The following is a description of a gene set: from publication Chen Y, Wang X (PMID 31504780) Genes predicted to be targets of miRBase v22 microRNA hsa-miR-3978 in miRDB v6.0 with MirTarget v4 prediction scores > 80 (high confidence targets). Human Gene Set: MIR3978 studied in species Homo sapiens, and this is the list of marker genes: GRM7, NRXN2, DISC1, ADAMTS9, BTBD8, SOCS3, SP3 (Sp3 transcription factor), MOSMO, STIM2, AP3S2, ATE1, NSD2, TMX4, CBFA2T2, KCNA5, KIAA0408, H2AZ1, SLC36A3, IRF8, ACVR2A, CASD1 (CAS1 domain containing 1), LCP1, ZC3H10, TNC, NETO1, CNOT6L, CLOCK, PKN2 (protein kinase N2), PER3, PHTF2, HACD4, IQCA1, OAS1, TOX, ARHGAP24, DDX6, GATM, NUP43 (NCBI Gene Id 79700), ADM, ANKRD42, CPNE3, RASSF8, HOMEZ, RORA, PURB, HSF5, GALE, GPR19, DPYD, NUFIP2, LMO3 (NCBI Gene Id 55885), DIAPH2, LETM2, POU2AF1, CNBD2, ACSL1, ARID4B, TM4SF4, DNAJB2, ATXN7, EIF5A2, TEAD1, MPC1, HOXD13, KDM3B (NCBI Gene Id 51780), SV2B (synaptic vesicle glycoprotein 2B), DOCK5, ZNF280C, PDE7A, ZNF84, RICTOR (NCBI Gene Id 253260), PRRC2B, GOLT1B, SERPINB8, HGSNAT, PDPK1, OPN3 (NCBI Gene Id 23596), NAMPT, SLC22A23, INSYN2A, ADAMTS5, GPLD1, AVL9, RGS21, RAD21, B3GNT5, ANGEL2, MMS22L, TSPAN2, IARS1, ARHGEF9, CHMP5, SPIN1, ARL1, PDE4DIP, SH3TC2, IER3IP1, KDELR1, PPIP5K2, DCK, ESR1, BMPER, AFF2, TMOD3, MYLK4 (NCBI Gene Id 340156), RCC2, S1PR3, FRMPD4, ARPIN-AP3S2, HOXA1, TLE1, WDR33, ACTL6A, ALPL, C2orf66, ONECUT2, IL1R1, RFXAP, PTPRD, RUNX1T1, SNAP47, HOOK3 (NCBI Gene Id 84376), KDM7A, CCDC3, TMEM132D, ARL10, FCHO2, ATXN3, GNRHR, PSD3, PRICKLE2, CHIC2, DLL1, STXBP6, PPP2R5C, ARSB, GABRA1, MFAP3L, KPNA4 (karyopherin subunit alpha 4), WIPI2, FARP1, GJB7, CCAR2, DNAH10, PPM1H (protein phosphatase, Mg2+/Mn2+ dependent 1H), TAF11, SMIM10, XRN1, IL1RAP, RPS6KA6, LMTK2, PRIMPOL (NCBI Gene Id 201973), PEX7, IMPACT, YPEL2, TRIM2, PTPDC1, AP1S2, MLEC, TRAPPC4, FRMD5, SLC9A9, SRPK2, PRDM16, SRGAP1, NEFH, JAKMIP2, OSBP2, GMCL1, HIPK2, VGLL3, PDE4D, TAPT1, CTXN2 (NCBI Gene Id 400369), ABCD2, ZNF792, PCDHGA7, CNR1, CHL1 (NCBI Gene Id 10752), WNK1, SULT1C2, CLEC7A, IDH3A, LIN7A, ZNF664, EPB41L2, INO80D, GDPD1 (glycerophosphodiester phosphodiesterase domain containing 1), EIF1B, GLRA2, SIT1, ZNF704, PRRG3, LY6G6C (lymphocyte antigen 6 family member G6C), BCAP29, SF3B1, B3GALNT2, LRRTM2, ZW10, KIAA1328, DGKH (NCBI Gene Id 8524), TMEM229A, AFF1, BCL2L13, SLC35B3, RERE, SNAP25, FKBP1A, ZNF609, OSBPL3, ISOC1, GCC2, MAF1, PBOV1, ZKSCAN8, ZNF597, C3orf70, RBM19, OGT, PLPPR4, NOL4, ZNF710, ZNF860, TDP1, SIAE, MEGF10, FSTL5, NRG1, BMP2, MYEF2, MAPT, TRANK1, XPR1, FBXO46, C21orf91, CREBL2, KATNA1, MYOCD, BTRC, JMY, PYROXD1, MTMR1, PJA2, SEPTIN6, PCDHB10, MBNL3, CHD1, TRABD2A, DACH1, DNAJC1, TNFAIP3, ATXN3L, RASSF2, DKK2 (dickkopf WNT signaling pathway inhibitor 2)